The following is a description of a gene set: The accumulation of DNA damage and mutations is considered a major cause of cancer and aging. While it is known that DNA damage can affect changes in gene expression, transcriptional regulation after DNA damage is poorly understood. We characterized the expression of genes in human primary fibroblasts after exposure to three different kinds of cellular stress that introduces DNA damage: 4-nitroquinoline-1-oxide (4NQO), gamma-irradiation, or UV-irradiation. Each type of stress elicited damage specific gene expression changes of up to 10-fold. A total of genes had similar changes in expression of 3-40-fold after all three kinds of stress. We examined transcription in cells from young and old individuals and from patients with Werner syndrome (WS), a segmental progeroid condition with a high incidence of cancer, and found various age-associated transcriptional changes depending upon the type of cellular stress. Compared to young individuals, both WS and old individuals had similarly aberrant transcriptional responses to gamma- and UV-irradiation, suggesting a role for Werner protein in stress-induced gene expression. Our results suggest that aberrant DNA damage-induced gene regulation may contribute to the aging process and the premature aging in WS. Human Gene Set: KYNG_ENVIRONMENTAL_STRESS_RESPONSE_DN species: Homo sapiens from publication Kyng KJ, May A, Stevnsner T, Becker KG, Kølvrå S, Bohr VA (PMID 15897889) All common down-regulated stress response genes (Human Environmental Stress Response, H-ESR)., and this is the list of marker genes: PDE3A, GNPNAT1 (glucosamine-phosphate N-acetyltransferase 1), SLC30A5, CEPT1, CTNND1, HSD17B10, SGPL1, USP1, CNKSR1, SOX9 (NCBI Gene Id 6662), FUT4, COL17A1, ZNF507, NCOR1, HNRNPC, SOX7, SYK